The following is a description of a gene set: The selective elimination of senescent neutrophils from the body by autoregulatory mechanisms. Human Gene Set: GOBP_NEUTROPHIL_CLEARANCE species: Homo sapiens, and this is the list of marker genes: ANXA1, XKR8, CCR2, HMGB1, AXL, MERTK